Given this list of marker genes PRM1, PHF13, CCNB1, MCPH1, TTN, HMGA2, H1-5, NCAPD3, SMC4, DFFB, NCAPH2, KMT5A, SMC2, FBXO30, H1-7, H3-3A, SMC5, H1-0, SMARCA5 (NCBI Gene Id 8467), TOP2A, PRM2, PLK1, TENT4A, H1-2, H1-9P, H1-10, NCAPD2, H1-3, BAZ1B, H1-6, CHMP1A, GPER1, H2BW1, AKAP8L, AKAP8, NCAPG, H1-4, ACIN1, H1-8, H3-3B, CDK1, ERN2, NCAPG2, H1-1, NCAPH, PRM3, NUSAP1, here is a description of the gene set: studied in species Homo sapiens The progressive compaction of dispersed interphase chromatin into threadlike chromosomes prior to mitotic or meiotic nuclear division, or during apoptosis, in eukaryotic cells. Human Gene Set: GOBP_CHROMOSOME_CONDENSATION